Given this list of marker genes HCCS, DCAF8, SNX12, PLXNA1, SMG6, GNA12 (NCBI Gene Id 654140), CPEB2, ZFAND2B (zinc finger AN1-type containing 2B), NPAS2, ZNF664, TRH, HSD17B12, VAV2, HEATR5B, SYNPO, KCNN2, ERCC1, FAM222B, DCX, PDAP1 (NCBI Gene Id 11333), BAP1, TOX4, APP, KLK4, ATCAY, ENC1, TFB1M, SOX10, ZDHHC9, ZFHX4 (zinc finger homeobox 4), MUC1, ELMO1, MAPKBP1, NDUFA6, FTO, PGRMC2, ZNF74, RPL22L1, BET1, here is a description of the gene set: from publication Chen Y, Wang X (PMID 31504780) species: Homo sapiens Genes predicted to be targets of miRBase v22 microRNA hsa-miR-6085 in miRDB v6.0 with MirTarget v4 prediction scores > 80 (high confidence targets). Human Gene Set: MIR6085